The following is a description of a gene set: Genes with intermediate-CpG-density promoters (ICP) bearing the bivalent tri-methylation marks at H3K4 (H3K4me3) and H3K27 (H3K27me3) in MEF cells (embryonic fibroblasts). Somatic cells can be reprogrammed to a pluripotent state through the ectopic expression of defined transcription factors. Understanding the mechanism and kinetics of this transformation may shed light on the nature of developmental potency and suggest strategies with improved efficiency or safety. Here we report an integrative genomic analysis of reprogramming of mouse fibroblasts and B lymphocytes. Lineage-committed cells show a complex response to the ectopic expression involving induction of genes downstream of individual reprogramming factors. Fully reprogrammed cells show gene expression and epigenetic states that are highly similar to embryonic stem cells. In contrast, stable partially reprogrammed cell lines show reactivation of a distinctive subset of stem-cell-related genes, incomplete repression of lineage-specifying transcription factors, and DNA hypermethylation at pluripotency-related loci. These observations suggest that some cells may become trapped in partially reprogrammed states owing to incomplete repression of transcription factors, and that DNA de-methylation is an inefficient step in the transition to pluripotency. We demonstrate that RNA inhibition of transcription factors can facilitate reprogramming, and that treatment with DNA methyltransferase inhibitors can improve the overall efficiency of the reprogramming process. Human Gene Set: MIKKELSEN_MEF_ICP_WITH_H3K4ME3_AND_H3K27ME3 from publication Mikkelsen TS, Hanna J, Zhang X, Ku M, Wernig M, Schorderet P, Bernstein BE, Jaenisch R, Lander ES, Meissner A (PMID 18509334) species: Mus musculus, and this is the list of marker genes: IDO1, NPY2R, MDH1B, CNTNAP1, PCSK1, YPEL4, PCDH20, PTH2R, SPTSSB, RNF207, ADM2, OPCML, LRRTM3, KCNJ2, PTPRR, KLHL1, NOL4, NPY1R, SYT1, SOX6, SACS, TAL2, MCHR1, USP44, ROBO2, MEIS1, PAK5, KCNA4, CORO1A, EXTL1, FGF10, NOL3, SERPINI1, TMEM100, FRMD4A, LIN28B, CALY, CACNB3